Given this list of marker genes C6, C8a, Hc, C8g, C9, here is a description of the gene set: studied in species Mus musculus Reactome Pathway: Terminal pathway of complement part of: Complement cascade This event has been computationally inferred from an event that has been demonstrated in another species.<p>The inference is based on the homology mapping from PANTHER. Briefly, reactions for which all involved PhysicalEntities (in input, output and catalyst) have a mapped orthologue/paralogue (for complexes at least 75% of components must have a mapping) are inferred to the other species. electronically inferred by orthology from the curated human pathway